The following is a description of a gene set: Mouse Gene Set: BILANGES_SERUM_SENSITIVE_VIA_TSC2 The tuberous sclerosis complex (TSC) proteins TSC1 and TSC2 regulate protein translation by inhibiting the serine/threonine kinase mTORC1 (for mammalian target of rapamycin complex 1). However, how TSC1 and TSC2 control overall protein synthesis and the translation of specific mRNAs in response to different mitogenic and nutritional stimuli is largely unknown. We show here that serum withdrawal inhibits mTORC1 signaling, causes disassembly of translation initiation complexes, and causes mRNA redistribution from polysomes to subpolysomes in wild-type mouse embryo fibroblasts (MEFs). In contrast, these responses are defective in Tsc1(-/-) or Tsc2(-/-) MEFs. Microarray analysis of polysome- and subpolysome-associated mRNAs uncovered specific mRNAs that are translationally regulated by serum, 90% of which are TSC1 and TSC2 dependent. Surprisingly, the mTORC1 inhibitor, rapamycin, abolished mTORC1 activity but only affected approximately 40% of the serum-regulated mRNAs. Serum-dependent signaling through mTORC1 and polysome redistribution of global and individual mRNAs were restored upon re-expression of TSC1 and TSC2. Serum-responsive mRNAs that are sensitive to inhibition by rapamycin are highly enriched for terminal oligopyrimidine and for very short 5' and 3' untranslated regions. These data demonstrate that the TSC1/TSC2 complex regulates protein translation through mainly mTORC1-dependent mechanisms and implicates a discrete profile of deregulated mRNA translation in tuberous sclerosis pathology. from publication Bilanges B, Argonza-Barrett R, Kolesnichenko M, Skinner C, Nair M, Chen M, Stokoe D (PMID 17562867) species: Mus musculus Genes translationally up-regulated by serum in MEF cells (embryonic fibroblast) lacking TSC2., and this is the list of marker genes: Spag5, Eif5b, Eif3a, Smarca4 (SWI/SNF related, matrix associated, actin dependent regulator of chromatin, subfamily a, member 4), Dicer1, Col3a1, Numa1, Col1a2, Nedd4, H2al2a, Uba6, Smg6, Ccn1, Kif1b, Ints15, Tubb2b, Ccdc88a, Thoc2, Kifc5b, Tbc1d16, Fam98b, H1f4, Thbs2, Glg1, Npm3, Fam234b, Eif3c, Snrpd3, Atp1a1, Ddx46 (DEAD box helicase 46), Gbf1, Ccn2